The following is a description of a gene set: Neighborhood of TNFRSF6 NULL in the MORF expression compendium Neighborhood of TNFRSF6 studied in species Homo sapiens Human Gene Set: MORF_TNFRSF6, and this is the list of marker genes: FAM13A, FAS, R3HCC1L, NR1I2, B4GALT6, TPD52, CELA2B, PTPRB, BRD4, KRT34, KRR1, RPS6KA5, GJB5, KRT2, TTTY1, CRHR1, GPR19, TMEM26, BCL2L11, RAD51D, SPATA2 (NCBI Gene Id 9825), CFH, HTR1E, HNF1A, ZBTB14, GRIK1, RXRG, AOC4P, MAGEA9, KDR, SIM2, ERCC4, PHOX2B, TBXT, MC5R, NOS2, RUNX2, COX6A2, TANC2, ABO, FBXL4, CEP162, NPFF, JRKL, CCL16 (NCBI Gene Id 6360), IL11RA, ZNF202, CPB2, PSG1, ARL3, GLRA3, LORICRIN, STAC, MSL3, FOSL1, H3C6, CADM4 (NCBI Gene Id 199731), ABCB10, LECT2, PHF10, ATP4B, DRC3, DMD, SOAT2, IPO9, FNTB, PHLDB1, ADAM20, EDIL3, FGF2, WBP4, FGF18, CD8A, BMP10, CDC73, NR3C2, ZNF200, ELAVL2, NTNG2, ZNF157, SULT4A1, P2RY10, ERC2-IT1, COLGALT2, VSTM4, GNG4, ZNF266, SERPINA4, SLC33A1, RREB1, COL19A1, GCM1, POU6F1, PPM1E, ZNF134, PGM3, OPCML, GCA, EXOC4, EPHB2, CXCL5, OR2B6, ITIH3, FLRT2, POLR1HASP, PDE6A, PVR, IGKV7-3, TBX19, PART1, COL8A1, ZBTB40, DBT, CYP2E1, FSHR, IL5, F2RL3, GPR18, ASB4, SLC4A8, ATP8B1, MDM2, IL16, CCR3, SUPT3H, TFDP2, AMMECR1, S100A5, ATF2, LGI1, PCM1, GPR171, TSSK2, SGPL1, SPA17, ZNF141, ABCC8, LDB3, ZSCAN26, SLC15A1, RORB, SLC22A6, CYP2D6, KLRC4, SLC6A2, FZD5, MLLT10, TENM4, PLPPR4, CALN1, CAMK4, RB1CC1, IFNA10, APOBEC1, ADAMTSL3, COQ7, OCM (oncomodulin), AQP7, ATXN3, CACNA2D1, SLC26A4, FUT1, HCRTR2, NHEJ1, MAP2, GUCY2F, MAGEA8